The following is a description of a gene set: studied in species Homo sapiens A process that modulates synaptic plasticity such that synapses are changed resulting in the decrease in the rate, or frequency of synaptic transmission at the synapse. Human Gene Set: GOBP_LONG_TERM_SYNAPTIC_DEPRESSION, and this is the list of marker genes: IQSEC2, DRD5, ADORA1, PENK, GRID2IP, CBLN1, SRF, GRID2, LILRB2, ABHD6, PLK2, DRD1, ARC, MAPT, AGER, SLC24A2, SORCS3, FMR1, SHANK2, STAU2, ADCY8, SHANK3, VPS13A, PICK1, KCNB1, PRRT1, CD38, GRIA1, SLC24A1, STXBP1, SORCS2, ARF1, GRM2